The following is a description of a gene set: species: Mus musculus Mouse Gene Set: GOBP_POSITIVE_REGULATION_OF_STEROL_TRANSPORT Any process that activates or increases the frequency, rate or extent of the directed movement of sterols into, out of or within a cell, or between cells, by means of some agent such as a transporter or pore., and this is the list of marker genes: Commd1, Nr1h3, Scp2, Pparg, Adipoq, Sirt1, Ces1b, Abca5, Lipg, Abca8b, Cav1, Abca8a, Abcg1, Abca7, Washc1, Eepd1, Apoe, Gps2, Ces1e, Abca12, Anxa2, Ces1f, Zdhhc8, Abca13, Abcb4, Nfkb1, Ces1g, Abca3, Abcg4 (NCBI Gene Id 76887), Pon1, Ptch1, Abca1, Ces1h, Nr1h2, Apoa1, Ces1c, Ces1a, Pltp, Lrp1 (low density lipoprotein receptor-related protein 1), Trem2, Nfkbia, Ldlrap1, Ces1d (carboxylesterase 1D)